Given this list of marker genes MIB1, TMEM198, FBXO42, SVIL (NCBI Gene Id 6840), PEG10, MTERF2, APRT, PDXDC1, BPHL, DACT2, IKBKE, TMEM106A, MXRA8, XPC, MARCHF8, DIO1, ATG4C, GTF3C4, PNRC1, LRP6, EDNRA, CARTPT (CART prepropeptide), LENG9, CDKN2B, MLKL, SERPINH1, A1CF, RB1, SUSD1, CTSK (cathepsin K), MARCHF4, SELENON, LRRC3, XDH, CTTN, LRRN4CL, INPP4B, MAB21L3, TNNT1, FBXO30, TMEM117, HAL, IGF2BP2, P2RX7, WWP1, TCAP, GRN, NOVA1 (NOVA alternative splicing regulator 1), SGCB, CDR2, TNIK, CREB3L4 (cAMP responsive element binding protein 3 like 4), CDH6 (cadherin 6), GPR160, BCAP31, NEU1 (NCBI Gene Id 4758), NLRC3, GALNT3, A3GALT2, FBXO32 (F-box protein 32), SEC61G, CCL8, MIR340, SEC14L2, RUFY3, WT1-AS, FOXC1, LY86, IGF1R, KLHL25, SYDE2, SCN1B, CHD7, DIS3L2, MYL6B, ERCC8 (NCBI Gene Id 2075), LY6G5C, PHTF2, CRYBA4, DOCK4, TACC2, POLR3D, CDKN2AIP, APOC2 (apolipoprotein C2), GCNT4, WDPCP, ANGPTL3, MAFK, MS4A4A, MYH10, AKIRIN1, DYNLRB2, GAMT, DDR2, PTN, EXOC6B, DBNDD2, TPCN2, USP2, BEST1, ANO4, ZMAT4, FOXO4, CD84, IGSF6, DCLRE1B (NCBI Gene Id 64858), CP, NEUROG3, TBC1D2B, MON2, SH3KBP1, GAS2L1, ATP6V0C, PALMD, ASH1L, NRP1, IL18BP, CLEC2L, TMCO5A, SLC28A2, ZCCHC3, CTSD, C6, TLR1, LRP1, DSEL, TUFT1, ZFYVE9, GSTM2, UTP23, ACSM2A, PGK2, OPHN1, HPGD, CADM1, ABCG2, CRIM1, RPS19BP1, DIP2B, HGF, PSENEN, PRUNE2, BCAR3, VSX2, LRRC8A, IRAK2, MECOM, AHNAK2, LAMP1, CD177, DKK3, MFAP3L, here is a description of the gene set: Dendritic cells (DCs) process and present self and foreign antigens to induce tolerance or immunity. In vitro models suggest that induction of immunity is controlled by regulating the presentation of antigen, but little is known about how DCs control antigen presentation in vivo. To examine antigen processing and presentation in vivo we specifically targeted antigens to the two major subsets of DCs using chimeric monoclonal antibodies. Unlike CD8+ DCs that express the cell surface protein CD205, CD8- DCs, which are positive for the 33D1 antigen, are specialized for presentation on MHC class II. This difference in antigen processing is intrinsic to the DC subsets and associated with increased expression of proteins associated with MHC processing. from publication Dudziak D, Kamphorst AO, Heidkamp GF, Buchholz VR, Trumpfheller C, Yamazaki S, Cheong C, Liu K, Lee HW, Park CG, Steinman RM, Nussenzweig MC (PMID 17204652) Genes up-regulated in cells from Flt3L Melanom injected mice: splenic DEC205+ dendritic cells versus B lymphocytes. studied in species Homo sapiens Human Gene Set: GSE6259_FLT3L_INDUCED_DEC205_POS_DC_VS_BCELL_UP